The following is a description of a gene set: Mouse Gene Set: GOBP_HARD_PALATE_DEVELOPMENT The biological process whose specific outcome is the progression of the hard palate from an initial condition to its mature state. This process begins with the formation of the structure and ends with the mature structure, whatever form that may be including its natural destruction. The hard palate is the anterior portion of the palate consisting of bone and mucous membranes. species: Mus musculus, and this is the list of marker genes: Tbx1, Fzd2, Dlg1, Sox11, Itgb6, Fzd1, Gabrb3 (NCBI Gene Id 14402), Itgb8, Mmp25, Foxe1